Given this list of marker genes MYMK, TBX5, PLXND1, REV3L, TBX3, ITPR1, MYMX, here is a description of the gene set: studied in species Homo sapiens Human Gene Set: HP_APLASIA_OF_THE_PECTORALIS_MAJOR_MUSCLE Aplasia of the pectoralis major muscle Absence of the pectoralis major muscle.